The following is a description of a gene set: studied in species Homo sapiens The appearance of macrophage inflammatory protein 1 alpha due to biosynthesis or secretion following a cellular stimulus, resulting in an increase in its intracellular or extracellular levels. Human Gene Set: GOBP_MACROPHAGE_INFLAMMATORY_PROTEIN_1_ALPHA_PRODUCTION, and this is the list of marker genes: ARG2, MEFV, SIRPA, TRPV4, TREM2, MCOLN2